The following is a description of a gene set: species: Homo sapiens Human Gene Set: GOBP_REGULATION_OF_GLIAL_CELL_MIGRATION Any process that modulates the frequency, rate or extent of glial cell migration., and this is the list of marker genes: TREM2 (triggering receptor expressed on myeloid cells 2), BMERB1, CX3CL1, NTN1, CERS2, CSF1, CCR2, ATP1B2, NF1, GPR183, STAP1, CX3CR1, RRAS, MIR221, MIR222, P2RX4, IDH2, CCL3, RRAS2, P2RY12, CRKL